The following is a description of a gene set: species: Mus musculus Mouse Gene Set: REACTOME_G2_PHASE G2 Phase, and this is the list of marker genes: Ccna2, Ccna1, E2f1, E2f3, Cdk2